Given this list of marker genes MIR210, LDHA, TP53, ACTN3, CAVIN3, ADHFE1, TIGAR, here is a description of the gene set: studied in species Homo sapiens The catabolic process that includes oxidation-reduction reactions for the generation of adenosine triphosphate (ATP) and primarily uses organic compounds as both electron donors and acceptors, without consumption of oxygen. Human Gene Set: GOBP_FERMENTATION